The following is a description of a gene set: studied in species Homo sapiens Human Gene Set: GOBP_POSITIVE_REGULATION_OF_TRIGLYCERIDE_CATABOLIC_PROCESS Any process that increases the frequency, rate, or extent of the chemical reactions and pathways resulting in the breakdown of triglyceride., and this is the list of marker genes: PNPLA2, AADAC, ABHD5, APOA4 (NCBI Gene Id 337), APOC2, DAGLB (diacylglycerol lipase beta), APOA5, FUT1